The following is a description of a gene set: studied in species Mus musculus Mouse Gene Set: GOBP_GUANINE_CATABOLIC_PROCESS The chemical reactions and pathways resulting in the breakdown of guanine, 2-amino-6-hydroxypurine, a purine that is one of the five main bases found in nucleic acids and a component of a number of phosphorylated guanosine derivatives whose metabolic or regulatory functions are important., and this is the list of marker genes: Urah, Gda, Urad, Xdh, Uox